The following is a description of a gene set: from publication Jeffrey KL, Brummer T, Rolph MS, Liu SM, Callejas NA, Grumont RJ, Gillieron C, Mackay F, Grey S, Camps M, Rommel C, Gerondakis SD, Mackay CR (PMID 16474395) Genes down-regulated in comparison of basophils versus NK cells. Human Gene Set: GSE3982_BASOPHIL_VS_NKCELL_DN In the present study we used Affymetrix oligonucleotide microarrays to produce gene transcription profiles for the major leukocyte types in humans. This comprehensive dataset enabled us to not only establish which genes were expressed in each leukocyte type, but also which genes were expressed in each subset after activation. The used of a comprehensive dataset of gene profiles from all the major human leukocyte subsets enabled a novel and powerful means for identification of genes associated with single leukocyte subsets, or different immune paradigms. studied in species Homo sapiens, and this is the list of marker genes: GRID2, DNAL4, PLAC8, PGC, TPMT, ANGPTL7, MRPL52, CAMK2A, TAS2R13 (NCBI Gene Id 50838), TBL3, ERVMER34-1, MYOZ1, STOM, GREM1, ITPKC, PPAT, PDGFD, LINC00472, TMEM223, PGLS, ELOVL6, P4HA2, ITPA, CLUH, FAM193A, RWDD2B, HPS1, SNX11, CYP11B1 (NCBI Gene Id 1584), BCAS4, PEX26, HNMT, AGTR2, SGPL1, COL11A1 (NCBI Gene Id 317718), GABRA2, TUBA8, GH1, CLN8, GABRD, OR7E36P, EDEM2, PRMT2, TIAM2, ABCF2, RASGRF1, CNDP2, AUP1, OR52A1, S100A7, PLA2G2F, GFOD2, SYCP1, VPS72, DNAJB12, LPXN, C1orf159, GUCA2A, MCCC2, METAP1, BLVRA (NCBI Gene Id 644), LPP, FARP2, MGLL, POLD1, MC1R, SLN, EXOC7, LTA4H, ATRNL1, SDAD1, SLC5A4, ENOSF1, REN, TMEM14A, ENPP4, DET1, GIMAP6 (NCBI Gene Id 79765), TRIM27, MDC1, WRAP53 (NCBI Gene Id 55135), SIDT1, LAMC3, INHBB, HOOK2, NEIL1, TOM1L2, STARD7, COLQ, MLXIP, LPAL2, SYNE1 (NCBI Gene Id 85448), PRIM1, GFOD1, ZNF767P, CELSR2, PDE6A, SKAP1, H3C11, UBIAD1 (NCBI Gene Id 7801), TARP, RHOF, NUDCD3, HDHD5, SEMA6C, IFT46, DCAF8, WIZ, IFNA4, BCS1L, GZMM, LPAR6, EIF2B3, DPH5, FBXO21, HS3ST2, RHBDF2, FAM3C, SPTAN1, KCNJ12, SULT1E1, SNTG1, EPB41L3, CDON, KLK6, ADCY2, KRTAP4-7, EXOSC7, AQP1, NOVA1, ADGRG1, CHL1, PSKH1, FMO6P, UPF1, APOO, GGA1, SIGIRR, SH3BGR, PVRIG, NLGN4Y (neuroligin 4 Y-linked), INPPL1, CACNA1F, EXT2, NPY1R, B4GALT5, KIF3C, GSTA1, MYO5C, TESK1, ENSG00000290731, GRM4, CHST4, MAPKAPK5-AS1, MOCS3, SLC26A6, GZMA, DNAJA4, PGAP3, CASQ1, GRM6, NPC1, CLNS1A, TUBB2B, MYH10 (NCBI Gene Id 4628), TFEC (NCBI Gene Id 22797, transcription factor EC), RNASEL, CEMIP, PRPS2, PLAAT3, DOHH, CPN2, ENDOD1, CDH12, IFNA16, LTBP3, PSG6, CAD, LILRA3, EFNA5, PLEKHG6, TACR3 (tachykinin receptor 3), LDB2, MAP1S, RNF8, SEPTIN9, SIRPB1, DNAI1, DENND1C, CCT4, OPTN, CTSC, PCDHGA1, RPS6KA4, CYP1A2, SYNGR4, PXMP2, CST7, NOX5